The following is a description of a gene set: studied in species Homo sapiens The process whose specific outcome is the progression of ventricular cardiac muscle over time, from its formation to the mature structure. Human Gene Set: GOBP_VENTRICULAR_CARDIAC_MUSCLE_TISSUE_DEVELOPMENT, and this is the list of marker genes: IRX3, POU4F1, TGFB1, MYBPC3, NAGLU, SMAD4, EDNRA, MBD3, ZMPSTE24, PKP2, COL14A1, HOPX, TPM1, TBX5, FGFR2, HEY2, BMP10, RYR2, TNNI3, FOXH1, TBX3, MED1, NRG1, DLL4, HAND1, TNNI1, ZFPM2, ADAMTS9, TGFB2, PTCD2, MBD2, PPP1R13L, PROX1, UBE4B (NCBI Gene Id 10277), MYH7, ISL1, DSG2, ID2, ENG, FOXC1, LRP2, SMAD7, FKBP1A, MYH6, MYL3, COL11A1, NOTCH1, NKX2-5 (NK2 homeobox 5), MYL2, CHD7, TNNT2, KCNJ8, KCNJ11, RBPJ, DSP, BMPR1A, FOXC2, NOG, TGFBR3, TGFBR1, TNNC1, HEG1